The following is a description of a gene set: Genes predicted to be targets of miRBase v22 microRNA hsa-miR-10398-5p in miRDB v6.0 with MirTarget v4 prediction scores > 80 (high confidence targets). studied in species Homo sapiens Human Gene Set: MIR10398_5P from publication Chen Y, Wang X (PMID 31504780), and this is the list of marker genes: P2RX6, PRICKLE2, EXTL3, SOCS2, CFAP47, RRM2, PRCP, IBA57, NECTIN1, TGM6, PLAGL2, SETD7, LHFPL4, PRTG, USP15, HDAC8, SRF, CCDC116, PPP1R16B, METRNL, RASSF8, AMOT, GRAMD1B, SMIM7, PDS5B, ERCC1, SNAP91, SKP2, ELAVL1, XRCC5, FRMPD4, STX7, RASSF2, ECE1, NNAT, GCSAM, OSBPL6, PRRT2, PYGM, ZNF672, ZMIZ1 (NCBI Gene Id 57178), NUTM2G, HEG1, ICMT, C1orf74, FLT1 (fms related receptor tyrosine kinase 1), USP30, VANGL1, TEX101, LDB3, SHISAL1, SLC16A2, CAMK2G, UCK1, CD1E, KCNAB2, CDC73, FAM131C, WIZ, HINFP, ENG, SIGMAR1, YIPF6 (Yip1 domain family member 6), CEP164, HECW2, GDNF, MPHOSPH8, RASL10B (NCBI Gene Id 91608), TAOK1, SGPP1, SLC20A1, SLCO2B1, CENPO, GFUS, SMARCD2, GON4L, ADCY1, POU2F2, KCNK3 (NCBI Gene Id 3777)